The following is a description of a gene set: studied in species Homo sapiens Human Gene Set: WP_EBOLA_VIRUS_INFECTION_IN_HOST Ebola virus infection in host, and this is the list of marker genes: ITGA3, NPC1, CLTCL1, GSN, ACTG1, RAC1, HLA-DQA2 (major histocompatibility complex, class II, DQ alpha 2), FLNA, PIK3CD, HLA-DPB1, HLA-DRB1, ITGAV, ITGA1, FLNC, VPS33A, ITGA5, IRF3, VPS4A, HLA-DOB, IRF7, TBK1, MAPK1, HLA-G, ICAM3, ACTB, TLR4, TIMD4, CLTC, RFC1, RASA2, CLTB, RELA, HLA-A, SCIN, ACTN1, VPS11, ADAM17, HLA-DQA1, FLNB, RHOB, HAVCR2, CREBBP, CAV2, AXL, KPNA1, HAVCR1, NPC2, VPS16, PIK3R3, EGFR, HLA-DMB, PIK3CB, TIAM1, HLA-B, NFKB1, CLEC10A, TYRO3, TSG101, STAT1, ITGB3, ASGR1, VAV2, AKT1, PIK3R1, IKBKE, PIK3CA, CLTA, MERTK, MAPK3, TOP1, VPS41, IL4, MFGE8, HLA-DQB2, C1QBP, CTSL, PRKRA, TPCN2, HLA-DMA, CD209, VPS39, ITGA2, CTSB, DAB2IP (NCBI Gene Id 84635), RHOC, RAB5A, RELB, CAV3 (caveolin 3), NEDD4, ITGA6, HLA-DPA1, RHOA, PAK1, RIGI, ACTN4, EPS15, HLA-DQB1, HLA-DRA, CLEC4G, IGF1R, CAV1, BST2, MBL2, NFKB2, RAB9A, CDC42, SOCS3, RAB7A, EIF2S1, HLA-E, PIK3R2 (NCBI Gene Id 5296), VPS18, HLA-C, EP300, TFAP2A, ITGB1, EIF2AK2, REL, GAS6, ITGA4, IQGAP1, CLEC6A, ICAM2, HLA-DOA, FOLR1, CD300A, HLA-DRB5, CLEC4M, HLA-F